Given this list of marker genes AARS2, UBD, ZCCHC17, C6orf62, DAD1, KHDC4, ITGAV, NEDD8, SF3B4, TMEM183A, PPL, CD93, CNIH1, ATP23, PPP1CA, SLC25A4, ELOVL6, NUP133, FAM83D, CFHR1, STT3A, EIF3F, TYMS, RHEB (Ras homolog, mTORC1 binding), FRAT2, SDHC, MAP1S, NUSAP1, FAT1, NCBP2, SCAMP3, DHX35, SOX13, VBP1, MGST3, COPE, PIGT, C1orf74, THEM6, PYCR2, DROSHA, RANBP6, TAX1BP1, CXCL9, RPA3, HDDC3, HSPA1B, CANT1, CDC5L, RPLP0, NOL7, SLCO2A1, STC1, P4HA2, PLVAP, MRPL48, ACBD6, HPS6, MRPL40, HMGN4, FAM174A, MPLKIP, TOR1AIP1, IFRD2, SNX27, ZNF106, BORCS7, GMDS, HPF1, ARV1 (ARV1 homolog, fatty acid homeostasis modulator), PAK1IP1, SEC61B, CRKL, TERF2, C7orf25 (NCBI Gene Id 79020), NUDT16L2P, NHSL3, TMED7, SNAP29, MCFD2, PPID, BTN3A2, POLR2C, EFL1, GTF2A2, WDR55, CDK5, UBA3, TIMM8A, ZNF329, TCFL5, RNF26, CPVL, VPS45, FRS3, RPS17, VOPP1, NANS, GLMP, CNIH4 (NCBI Gene Id 29097), SERPINB1, ATP6V0E1, GMNN, RBBP5, TCHP, APOLD1, LYAR, RPS21, SH3PXD2A, OSTC, UBE2Q1, RPL26L1, ENOPH1, CHPT1, RAMP1, TMTC4, APEX1, YARS2, EARS2, SRSF3, CRY1, SERTAD2, KLHL8, NOP10, ANKRD49, RRP36, WBP1L, LRRC8D, SAV1, AP3B1, SEC61G, ILF2, PRC1, ACTL6A, GABARAPL2, NDST1, TOM1L1, RDH10 (NCBI Gene Id 157506), HAX1, RIMOC1, STT3B, GET1 (NCBI Gene Id 7485), COL1A1, HEY1, SENP2, VPS28, RPL23A, SERP1, DOLK, TRIM22, PSMD10, SEC13, SFXN2 (sideroflexin 2), SLC38A9, TAF12, MAGOH, DCAF12, PTTG1IP, DNAJC9, MFAP1, STXBP6, DENND10, GSTA1, C8orf33 (chromosome 8 open reading frame 33), CCDC107, COX6A1, SBF1, AHCY, MID1IP1, TFB2M, TIPRL, SREBF2, GTF2H4, APIP, MRPL58, PDE12, OXA1L, CYP2A7, CES1, ZNF664, C1orf131, RAB5IF, SKIC8, VAMP5, IL10RB, DPH3, GNMT (glycine N-methyltransferase), IRF6, POGK, GID8, GALNT18, MYDGF, MYLIP, RGS5, KLF15 (KLF transcription factor 15), MTF1, PGK1, FZD4, PTPN1, TMEM9, MLH1, CYBRD1, CNPY3, PPP1R16A, HLA-F, NTPCR, EIF3M, TIGD5, GMPS, CRIPT, UFM1, ESF1 (NCBI Gene Id 55639), PDCD5, UCHL5, NUCB2, COA4, SIMC1, TATDN1, TRMT112, LSM10, GINS2, NUDCD2, MUC13, FKBP5, ZNF319, FGGY, CHAMP1, C14orf93, MTX1, SSR1, TIMM29, UFC1, CMSS1, NABP2, FKBP11, HAUS4 (NCBI Gene Id 54930), NOPCHAP1, TFG, TMCO3, SPTSSA, ATP1B1, DNAJC14, MAPRE1, RPL10A (ribosomal protein L10a), RFX5, SNAP47, SLC9A6, DDAH2, HIGD1A, APEX2, ADAT1, PSMB2, ZMPSTE24, WDR45B, PKP2, MRPL18, PHPT1, SEC23B, SRPK1, TAP1, PSMG1, SPARC, MRPL33, TM2D1, IGFLR1, PCOLCE2, ARF3, NRDC, TMEM147, ARHGAP12, GTF3C2, F5, NPC1, MMGT1, PIGC, SOWAHA, ELOC, MDC1, TRAPPC4, ZMAT3, RCN2, CCDC167, ZFAND1, CNN3, HARS2, STAMBPL1, CSTB, FOXQ1, ANAPC10, UGT2B4, NUP205, SLC29A3, MSH6, SUN1, KLF13, CFHR5, KLHL12, EPRS1, PEA15, TMEM184B, ADGRF5, SEC14L2, CCDC71, TWF2, NSMCE2, CBX7, NAA10, NUP153, USP11, EIF2B1, PECAM1, LRIG1, TMEM199, HNRNPR, TOR1B, AURKA, RPL36AL, ASAP2, VWF, NUP37, ARL2BP, CETN2, CPNE8, UBLCP1, TDRD7, LYPLAL1, PPIC, METTL3, XPR1, MAFB, LMNA, PFDN6, DDX21, EIPR1, NUP42, DRAM1, SDF2L1, EIF1B, GTF2IRD2B, RRP15, ERLEC1, COP1, TYMSOS, SNRPB, MRPS18B, PURA, CTR9, SPTAN1, ADAMTS4, SMARCC1, CCDC91, LAGE3, MRPL24, BMI1, MCM3, TRMT1L, MARCKS, BOLA1, SLC2A10, SELENOT, MTM1, DEPTOR, SAP30L (NCBI Gene Id 79685), SLC6A1, NDUFA8, GPR137B, LYZ, CDC42EP4, FAM20B, TUSC2, CCT8, PSME3, CNEP1R1, DMAC2L, GSTA2, SPCS1, KDELR2, MRPL36, CYYR1, KDM5B, PRODH, GOLPH3L, IFTAP, MRPS18C, IARS2, ZSCAN16, DOCK1, CUL2, POLR2H, NDUFB6, GRN, GOLT1B, C16orf87, SOX18, SSC4D (scavenger receptor cysteine rich family member with 4 domains), KPNA2, THY1, MKRN2, CDC20, ITPR2, HTATSF1, MPC2, UBB, HPRT1, SLC17A3, ARL1, SRSF2, NUP62, EXOSC5, RPL26, NHP2, PIP4K2C, AMDHD1, CHCHD1, CHMP5, H2AC6, GPKOW, MARS1, NDUFA4L2 (NDUFA4 mitochondrial complex associated like 2), SNRPC, EMC4, GBE1, PSMC6, CSTF2, XPO1, ZHX3, ANO6, CPQ, RTRAF, LCN2, RESF1, KATNIP, KIAA1191 (KIAA1191), SMC3, EXOSC3, MICOS13, WDCP, SLC49A4, MCTS1, AKR1C3, SASH1, BZW2, F13B, RPS5, MIEF1, LARS1, PSMB4, ETNK2, LAMTOR1, IPO9, CHMP1B, NUDT2, COL4A1, KLHL20, TINF2, LSM4, S1PR1, RANBP1, CENPN, SP2, IDI1, FLOT1, RBBP7, PEX2, EFNB2, UBE2T, TSPAN14 (tetraspanin 14), TARBP1, PSMD6, TFDP1, RAB3IP, EIF4A3, RUVBL2 (NCBI Gene Id 10856), SNU13, WIPI1, PRRC2C, CDH5, GPAA1, S100A10, NOA1, ADGRV1, H3-5, DESI1, DNMT1, GBP4, CDR2, DVL3, SCNM1, RPL35A, CANX, RPS27A, POLR3E, HSPA1A, SUPT4H1, H2BC12L, CMC1, YIF1B, MED7, SLC4A1AP, IRX3, KIFAP3, FADD, UCK2, TRIP4, DOCK10, ZMYND19, RBM4B, MRPS27, IK, H2BC21, ALG14, DHX16, METAP1, GBA1, INIP, HSD17B8, MEA1, TSEN15 (NCBI Gene Id 92120), RBP7, ATRN, H2AZ1 (NCBI Gene Id 3015), SLC39A1, TFIP11, COL5A2, ZNF7, GTPBP4, RPS4X, LSG1, RTCA, MTFR1, DYNLL1, ARFGAP3, EIF2D, EPM2AIP1, PPP2R5A, DPY30, NAT9, RND1, SDF2, BTG3, TRIB2 (tribbles pseudokinase 2), RPL15, SURF1, ISCA1, HLA-B, UBE2N, TBC1D2, PIGB, HSPH1, PRICKLE4 (NCBI Gene Id 54772), TSG101, KATNB1, NR2C2AP, CLP1, MIF4GD, RFC4, LRATD2, SPCS2, HOMEZ, AIF1L, DTYMK, FABP4, EIF3J, PDCD7, AFG2B, GNG5, RUNDC1, TMEM38B, IPO4, LRRC42, KLHDC9, H1-2, TMEM248, PAPSS1, RMI2, VPS29, XXYLT1, NDUFA12, MAN1C1, PPM1K (NCBI Gene Id 152926), NAGS, C1orf198, MFSD14B, BCAT2, TMED10, DRG1, CD9, MAP2K2, CCNA2, EEF1E1, PHACTR4, GPN1, PTBP3, GEMIN6, COPA, SPARCL1, RIOK2, ARHGAP19, XRCC6, ROCK2, HSD17B11, PEX19, TEAD2, HS1BP3, CYBC1, CLN3, NDUFAF2, RPA1, GOLGA4, CKLF, METRN, SLC23A1, MORF4L2, GMFB, DYNLRB1, YEATS2, TAGLN2, DUSP12, ATP2A2, TMEM258, PIGY, MAN1A2, SNRPF, PDCD2L, SLC26A6, CYSTM1 (NCBI Gene Id 84418), SLC30A10, SDC2, MAPK1IP1L, MRPS17 (NCBI Gene Id 64958), RBM34, FAM219B, CCL5, PPOX, KCTD3, TUBB4B, SATB2, ADIPOR1 (NCBI Gene Id 95409), NAGA, TXNRD1 (thioredoxin reductase 1), EIF2A, PPIAL4A, LMO2, H2AC18, ZMYM6, ZMAT2, RPS15A, CDK2AP2, VAMP7, TESK1, NDUFB3 (NADH:ubiquinone oxidoreductase subunit B3), AP1S1, NEDD4L, ZSCAN18, H4C14, BTF3, DNAJC19, MTX3, NUP107, PSEN2, CKS2, BIVM, KIFBP, METTL13, ODC1, C1orf53, PIGM, ACP1, MPV17, DENND5B, DDX46, RRS1, PFN1, SERPINH1, AMZ2, CCT2, IDH1, ALG1L1P, METTL25B, PRPSAP1, SLC35B1, TP53BP2, C12orf57, LIX1L, PSMD2, EIF4ENIF1, USP34, TFRC, TMEM167B, FOXC1, TRIM27, COPB2, TUBA1A, VPS35, PLGRKT, LAMC1, ACE2, SLC35F6, LLPH, GHDC, TSNAX, SEC24D, ATAD1, SWAP70, TUBA1C, TTC32, YIPF1, H2BC12, TARS2, POLR2J3, GNPAT, PLA2G4C, WRAP73, MRPL9, IFIT2, BLVRA, GNG11, AFF4, HLA-C, PPAT, RPP21 (NCBI Gene Id 95307), SH3D19, SKIC3, ATG3, MCM4, RPS13, PIR, ANXA2R, RDH14, AP3S1, MCM5, DNAJB11, CD59, TMED4, POMGNT2, UBTD1, TEF, TMEM14A, CCDC117, DENND5A, CREB3L2, JARID2, REXO2, BPNT2, CKS1B, BBX, TBCE, COMMD3, TIMELESS (NCBI Gene Id 8914), ZNF791, SLC35E1, MRPS23, SUV39H1, GGPS1, TCTN1, ATP6V0C, CYP4F2, H2AC20, NCOA6, MAN2B1, RPL30, MAPKAPK3, IGBP1, MPV17L, ETF1, IRAK1, C1orf35, LSM3, ZBTB9, PPP1R2, HMGB2, ABHD5 (NCBI Gene Id 51099), GNG10, ZCCHC9, SLC33A1, TK1, HYOU1, RMI1, ABHD16A, CKAP4 (NCBI Gene Id 732190), ACOT9, ARPP19, RPS7, C1QBP, EPHX1, BFAR, FAM120AOS, CENPX, SF3B6, VPS25, TBL2, AQP11 (NCBI Gene Id 282679), SET, GPC3, NUDT5, HSPA14, NRAS, PTPN12, UQCRB, DHX29, PPA1, PSMB5, TMEM14C, NAA80, SRXN1, RMC1, PARP4, CCDC51, SLC50A1, ARSA, DARS2, H2AX, NDUFB5, NUDT1, CORO1B, MRPS21, DEGS1, ANKMY2, RNASEH2A, PDIA6, RAB22A, XPOT, GTF2IRD2, DCTPP1, C6orf226, DPCD, CUEDC2, SLC51A, PTRH1 (NCBI Gene Id 138428), GSTO1, RPS25 (ribosomal protein S25), THAP11, LPGAT1, YAE1, ASPM, SSR2, FARS2, WASHC5, TMOD1, MYO5C, DSN1, PMS2P5, USP3, USP30, CTCF, ACBD3, PARP1, NDUFA7, PRORP, ACLY, CAP2, RSRC1, COX7A2, UBE2S, GSKIP, TBC1D16, UBE4B, HSP90AB1, RAP2A, SDCBP, DTL, DPH5, CASK, here is a description of the gene set: Genes up-regulated in liver tumor compared to the normal adjacent tissue. Human Gene Set: ACEVEDO_LIVER_TUMOR_VS_NORMAL_ADJACENT_TISSUE_UP species: Homo sapiens from publication Acevedo LG, Bieda M, Green R, Farnham PJ (PMID 18413731) There is widespread interest in efficient characterization of differences between tumor and normal samples. Here, we show an effective methodology for genome-scale characterization of tumors. Using matched normal and tumor samples from liver cancer patients, as well as non-cancer-related normal liver tissue, we first determined changes in gene expression as monitored on RNA expression arrays. We identified several hundred mRNAs that were consistently changed in the tumor samples. To characterize the mechanisms responsible for creation of the tumor-specific transcriptome, we performed chromatin immunoprecipitation on microarray experiments to assay binding of RNA polymerase II, H3me3K27, and H3me3K9 and DNA methylation in 25,000 promoter regions. These experiments identified changes in active and silenced regions of the genome in the tumor cells. Finally, we used a virtual comparative genomic hybridization method to identify copy number alterations in the tumor samples. Through comparison of RNA polymerase II binding, chromatin structure, DNA methylation, and copy number changes, we suggest that the major contributor to creation of the liver tumor transcriptome was changes in gene copy number.